The following is a description of a gene set: Putative targets or partners of EZH2 in hematopoietic stem cells. The molecular mechanism responsible for a decline of stem cell functioning after replicative stress remains unknown. We used mouse embryonic fibroblasts (MEFs) and hematopoietic stem cells (HSCs) to identify genes involved in the process of cellular aging. In proliferating and senescent MEFs one of the most differentially expressed transcripts was Enhancer of zeste homolog 2 (Ezh2), a Polycomb group protein (PcG) involved in histone methylation and deacetylation. Retroviral overexpression of Ezh2 in MEFs resulted in bypassing of the senescence program. More importantly, whereas normal HSCs were rapidly exhausted after serial transplantations, overexpression of Ezh2 completely conserved long-term repopulating potential. Animals that were reconstituted with 3 times serially transplanted control bone marrow cells all died due to hematopoietic failure. In contrast, similarly transplanted Ezh2-overexpressing stem cells restored stem cell quality to normal levels. In a genetic genomics screen, we identified novel putative Ezh2 target or partner stem cell genes that are associated with chromatin modification. Our data suggest that stabilization of the chromatin structure preserves HSC potential after replicative stress. Mouse Gene Set: KAMMINGA_EZH2_TARGETS from publication Kamminga LM, Bystrykh LV, de Boer A, Houwer S, Douma J, Weersing E, Dontje B, de Haan G (PMID 16293602) species: Mus musculus, and this is the list of marker genes: Dntt, Prc1, Cul2, Mki67, Xpo1, Hat1, Eed, Rbl1, Dbf4, Nek2, Rpa3, Pcna, Kpna2, Aurkb, Tacc3, Mad2l1, Mcm2, Nap1l1 (NCBI Gene Id 53605), Topbp1, Ect2, Ipo5, Ppp1cc, Mcm4, H2az1, Pole2, Prim1, Top2a, Tfdp1, Cdca7, Ccnb2, Rfc1, Gmnn, Smc2, Cdca5, Mcm3, Aurka, Ahcy, Setdb1, Nusap1, Smc4, Rrm1